Given this list of marker genes Xrcc5, Brca1, Fanci, Xrcc6, Atm, Phf21a, Palb2, Ascc2, Rnf168, Ascc3, Ascc1, Rcor1, Fancd2, Xrcc4, Trp53bp1, Brca2, Nhej1, Paxx, Kdm1a, Lig4, Dclre1c, Prkdc, Cyren (NCBI Gene Id 78412), here is a description of the gene set: A protein complex involved in DNA repair processes including direct reversal, base excision repair, nucleotide excision repair, photoreactivation, bypass, double-strand break repair pathway, and mismatch repair pathway. studied in species Mus musculus Mouse Gene Set: GOCC_DNA_REPAIR_COMPLEX